Given this list of marker genes FLCN, FNIP1, SOS2, NUDT21, SOS1, NOTCH1, HES1, HES5, here is a description of the gene set: Human Gene Set: GOBP_REGULATION_OF_PRO_B_CELL_DIFFERENTIATION Any process that modulates the frequency, rate or extent of pro-B cell differentiation. studied in species Homo sapiens